The following is a description of a gene set: The aggregation, arrangement and bonding together of a set of components to form the spindle during meiosis I of a meiotic cell cycle in females. An example of this is found in Drosophila melanogaster. Mouse Gene Set: GOBP_SPINDLE_ASSEMBLY_INVOLVED_IN_FEMALE_MEIOSIS_I species: Mus musculus, and this is the list of marker genes: Fbxo5, Aurka, Ccnb2, Cenpe, Ndc80